The following is a description of a gene set: Any process that inhibits or decreases the rate of DNA recombination during mitosis. studied in species Mus musculus Mouse Gene Set: GOBP_NEGATIVE_REGULATION_OF_MITOTIC_RECOMBINATION, and this is the list of marker genes: Zscan4c, Blm, Terf2, Ankle1, Mlh1